Given this list of marker genes GUSB, here is a description of the gene set: Reactome Pathway: MPS VII - Sly syndrome (CS/DS degradation) part of: Mucopolysaccharidoses species: Homo sapiens Mucopolysaccharidosis VII (MPS VII, Sly syndrome, beta-glucuronidase deficiency; MIM:253220) is an autosomal recessive lysosomal storage disease characterized by a deficiency of the enzyme beta-glucuronidase (GUSB; MIM:611499) which would normally cleave glucuronide residues from dematan sulphate, keratan sulphate and chondroitin sulphate, resulting in build up of these GAGs in cells and tissues. The gene encoding GUSB is 21 kb long, contains 12 exons and gives rise to two different types of cDNAs, through an alternate splicing mechanism. It maps to 7q11.21-q11.22. The phenotype is highly variable, ranging from severe causing death, non-immune hydrops fetalis to mild forms with survival into adulthood. Most patients with the intermediate phenotype show hepatomegaly, skeletal anomalies, coarse facies, and variable degrees of mental impairment.